The following is a description of a gene set: Adult onset Human Gene Set: HP_ADULT_ONSET studied in species Homo sapiens Onset of disease manifestations in adulthood, defined here as at the age of 16 years or later., and this is the list of marker genes: DNAJC5, RPGR, TERB2, INF2, ESR2, CACNA1A, CTNS, IFT140, CATSPER2, LGI1, RBM20, HJV, KLHL7, FBN1, MATR3, TULP3, LYST, RCBTB1, CAV3, POGLUT1, SPG7, ATP5MC3, MSH3, RNF216, DES, NOTCH2NLC (NCBI Gene Id 101060315), MPV17, CRYBA2, BAG5, HMCN1, MFRP, DRC1, SETX, KCNJ5, GPIHBP1, NRIP1, SLC37A4, DDX41, UCHL1, AOPEP (aminopeptidase O (putative)), SLC2A10, SDHA, ABCC8, CFHR3, PRPF8, NPHP1, CARD9, PLG, SUFU, SSX1, ERLIN2 (ER lipid raft associated 2), CFAP58, MECR, HPRT1, RPS4Y2, DYSF, KLHL3, RNASEL, MT-TT, LRP5, STK33, HSFY1, GNB3, SPTLC2, CYLC1, THSD4, RFXANK, ATP1A1, KLKB1, UMOD, FN1, TMEM126B, CIB1, TLR8, NLRP7, WRN, SLC44A4 (solute carrier family 44 member 4), CEL, OBSCN, FIG4, SOST, ELOVL4, DPY19L2, KCNH2, BVES, ZFHX3, PNPLA6, PLIN4, ZSWIM7, DMD, FHL1, PKP2, ITPR3, CD164, ABCG8, SCN4A, TLR7, CPT1C, GNB4, SLC30A8, MYPN, FOXC1, RRAGD, COL2A1, SMAD4, EIF2AK4, ATXN2, RILPL1, RAB39B, SOCS1, ATL3, KLHL24, FTL, TNNT2, SERPINH1, ITPR1, LIPC, NR3C1, SEC61A1, CNTNAP2, BPY2, TNFRSF13C, GCM2, CACNB4, PANK2, ARL2BP, PLD3, CADM3, ANO5, CASQ2, HSPB1, IMPG2, ABHD12, SDHB, SLC39A14, SYCP2, G6PD, KRAS, TTC19, ERCC6, TRPM7, SLC19A3, FGA, BRCA2, USP26 (NCBI Gene Id 83844, ubiquitin specific peptidase 26), RAPGEF2, SLC4A4, SPATA22, GPD2, SLC22A12, OPTN, WNT4, ANLN, PNKP, MEIOB, NR0B1, MSH6, KCNQ1, LHB, RAX2, LMNA, LRRK2, MAPKBP1, BSCL2, CAV1, SERPINA6, MORC2, PRKN, STAT1, HKDC1, HINT1, ABCC9, ADGRG2, FGF14, NOL3, KCNJ2, RNF170, ANXA5, NEK8, TTR, DNAJB6, SDHC, DNAH17, M1AP, MME, RETN, SLCO2A1, FOXL1, CCND1, PMP22, SGO1, CHRNA1, BRCA1, COL6A2, NPC1, MCM6, MYORG, MYL2, PRKG1, NOTCH3, AURKC, POLRMT, THBD, VPS16, HCN4, ATP7B, CLCN1, MEI1, TMTC4, UBA1 (ubiquitin like modifier activating enzyme 1), TNNC1, DIAPH2, CDH1, FBLN5, LRIF1, FKBP6 (NCBI Gene Id 8468), CHEK1, BMP6, LBR, GJC2, SMN2, PMVK, LITAF, DNAJB11, FARS2, GATAD1, DYRK1B, KCNJ11, TAF1, STARD7, ZMYND15, CLN6, CATIP (ciliogenesis associated TTC17 interacting protein), MCAT, F8, COQ2, FHOD3, EPAS1, LIG3, JPH2, CACNA1I (calcium voltage-gated channel subunit alpha1 I), TARDBP, IFIH1, GK (glycerol kinase), CASR, NEFL, COQ8B, SLC4A11 (solute carrier family 4 member 11), TGM6, SLC26A1, F5, NTHL1, FOXE3, TTC21A, SCN2B, DNMT1, CYP27A1, DRD5, TENM4, SMN1, GABRA3, TECRL, PDE11A, LMF1, C1QBP, PATL2, LOX, PLIN1, TRPC3, NT5C3A, MYBPC3, PDGFB, GALC, TBP, ATXN1, VEZF1, PNPLA2, RTEL1, EIF2B3, AARS2, ERBB4, CCDC62, ARMC12, TNNT1, HNRNPDL, ANO3, NLRP2, ANO10, DNAJC30, LIG4, CDC20, THOC1, CCDC88C, MPZ, AKT1, HMGCR, USP9Y, POF1B, HAMP (hepcidin antimicrobial peptide), TBC1D24, TAPBP, CC2D2A, TRPC6, TCF7L2, GIPC1, STAG3, LYZ, TAF4, SCNN1G, NFKB1, HK1 (NCBI Gene Id 59333), C1QTNF5, TEX11, SNCA, TNC, DNMT3B (NCBI Gene Id 1789), APOA1, RIPOR2 (RHO family interacting cell polarization regulator 2, NCBI Gene Id 9750), TCF4, SLC26A8, PTEN, PRPF4, OTC, TNFAIP3 (TNF alpha induced protein 3), ABCA7, SMARCA4, SFRP4, SH3BP2, WEE2, CRYAB, ITM2B (integral membrane protein 2B), CFI (NCBI Gene Id 3426), SLC4A3, LMX1B, PSEN2, CPOX, PIGA, DSC2, DAZ2 (NCBI Gene Id 57055), NUTM2B-AS1, MAPKAPK3, CORIN, SYCP2L, SLC4A1, NLRP5, YEATS2, DHTKD1, PRPH2, GNAL, SRPK3, SEPTIN12, MYH6, PRRT2, CDH23, ZP1, XRCC2, SCN5A, CEP78, RP1L1, PPOX, RBM12, PDK3, HFM1, MAPK8IP1, SMPX, CCDC146, SPTLC1 (serine palmitoyltransferase long chain base subunit 1), SCN4B (sodium voltage-gated channel beta subunit 4), RFC1 (replication factor C subunit 1), PIK3CA, RAF1, MMACHC, MFAP5, ARMC5, GDF9, KCNH5, KIF5A, COL6A3, IL36RN, CYP11B1, CAPNS1, POLE, SYNE1, MSH5, LAMA2, VPS35 (NCBI Gene Id 91808), ICOS, FAT2, TDRD9, TRIM32, TBC1D8B, SDHD, MFSD8, STRC, PABPN1, MPEG1, AARS1, RPL10L, KASH5, COL4A3, NEFH, CYLD, TWNK, DAZ3, UBQLN2, GCGR, SNCAIP, RP2, SEC23B, ATN1, DNHD1, PPP1R3A, SLC17A8, CDY1, PLAU, NAF1, LRRC23, ZNF687, SEMA3A, ATP1A2 (NCBI Gene Id 93186), EFEMP1, HTRA1 (NCBI Gene Id 5654), BCL10 (NCBI Gene Id 8915), PRPF6, JAK2 (Janus kinase 2), HNF4A, BEAN1, BLVRA, CHD8, SOX9, SOD1, GCNA, GBE1, ZP3, APP, MARCHF6, VCY, NPTX1, STT3A, PRDM10, ELMOD3, ADH1C, TERC, DSG2, ATP13A2, SLC25A4, TUBA4A, SYNJ1, C9, TRDN, CAPN1, REEP6, MAP1B, GGCX, CNBP, HNF1A, NEXN, GNPTAB, HROB, TUBB4A, FDPS, ARHGEF18, RBMY1A1, APPL1, PIK3R5, SNORD118, NHLRC1, VCP (valosin containing protein), SCO2, SEC63, TBK1 (NCBI Gene Id 29110), GGN, C14orf39, PDHA2, AAAS, MGME1, PDX1, PHKA1, CYP7B1, IRS1 (insulin receptor substrate 1), SUN5, NAGLU, DNAH8, GSN, REC114, HSPB8, MBD4, GBA1 (glucosylceramidase beta 1), CT55, XKRY, HRG, MAPT, MYH7, POT1, VPS13D (vacuolar protein sorting 13 homolog D), CFHR1, AAGAB, ACTL7A, PARN, DPM3, NR2E3, FSHB, TBX3, KCNJ18, TTBK2, ATXN10, MAFA, ATP1A3, CSF1R, TP63, ALDH5A1 (NCBI Gene Id 7915), TPP1, HAVCR2, LCAT, PMP2, PLAAT3, PALB2, MCM2 (minichromosome maintenance complex component 2), BRDT, QRICH2, CACNA1C, TCAP, VSX1, TEX15, IGF2BP2, EIF4G1, TMEM240, SPACA1, FANCM, SCN1B, GDAP2, SLC20A2, CCNF, CLEC3B, TSGA10, JUP (NCBI Gene Id 3728), LRP12, SPTAN1, KCNE1, DCTN1, SAMD12, DNAJB2, CLDN16, FBXO43, NF2, ABCC1, IRS2, KCTD17, TREX1, APTX, MEFV, AFG3L2, THAP1, NAA60, SLC17A9, JAG2, C19orf12, SPAG17, DAZ1, CTNNA1, MTOR, CATSPER1, VAPB, PRDX3, YARS1, ACR, TOP3A, USP48, GANAB, SAMD9L, SCN3B, MICAL1, AMACR, JPH3, HNRNPA1, MARS1, FMR1, LPL, BAP1, VCL, HNRNPA2B1, SH3TC2, PYGM, SGCD, RIGI, DIABLO, AP5Z1, THSD1, KIF1B, TRNT1, ANKH, SLC4A2, VHL (von Hippel-Lindau tumor suppressor), SASH3, TBX18, TIE1, ASTL, HLA-DRB1, RPGRIP1, NRCAM, HMGA1, TMEM43, ATP2B2, CHMP2B, PLA2G6, TERT, DSP, GBF1, ANXA11, DNM1L, MANF, TPM1, TTLL5, ZEB1, MUC1, CDH2, KCNE2, TOR1A, DIAPH3, CCIN, ALG10B, CHCHD2, SERPING1, LZTR1, IQCN, MED25, TSPOAP1, ELOVL5, SMCHD1, NEUROD1, MEN1, DNA2, PAX4, VAMP1, ABCA4, MOG, ACD, SHANK3, SMARCB1 (NCBI Gene Id 6598), GNAS, INS, WASHC5, MTNR1B, PRKRA, DTNA, PRKCSH, ALG5, TFG, MCCC1, DAB1, VRK1, MFN2, WFS1, NRL, PPARG, KPNA7, ATP6AP2, CHRNA2, RP1, CNNM2, MN1, TNPO3, NT5C2, HNF1B, ACTG1, FLNC, NF1, CFAP43, PTF1A, SLC19A2, APC, FKTN, BLK, STOX1, GATA2, INSR, CFAP251, SCN1A, GRN (granulin precursor), DGKE, SCN10A, TAF4B, STIM1, RRM2B, KCNA5, WDR19, SLC2A2, TIMP3, NDUFS2 (NADH:ubiquinone oxidoreductase core subunit S2), PRLR, AK7, PSEN1, ATP6V0A1 (NCBI Gene Id 535), TNNI3 (troponin I3, cardiac type), FSIP2 (NCBI Gene Id 401024), PAX2, PRKAG2, PDGFRB, KCNC3, SCD5, SPRY2, NOS3, PTPN1, PIGT, MYZAP, BMPR2, XRCC1, LIPE, COL4A1, POLG, PPP2R3C, ACVR1B, POLG2, C3 (NCBI Gene Id 12266), ALDH18A1, XK, LDB3, REEP1, ENPP1, C2CD6, KCNK3, AIP, SLC25A13 (NCBI Gene Id 10165), EIF2AK2, UNC119, HLA-DQB1, TK2, SCARB2, EEF2, GARS1, GNAI2, PLEKHG5, KCND3, CFAP61, XPR1, PRDX1, SMPD1, FZD4, GCK, EXTL3, CASK, CDY2A (chromodomain Y-linked 2A), BBS2, AUH, ZFP36L2, MSH4, HSPB3, AKT2, CTSF, VPS13C, DRAM2, ATP11A, TRPV4, TRPM3 (NCBI Gene Id 80036), ATL1, CFH, ABCB4, RNASEH1, STK11, HGSNAT, CLCN2, TSC1, PRDM16, LRP6, PRNP, TOR1AIP1, OXGR1, PDE8B, CBFB, PSAP, TRMT5, SOHLH1, KNG1, ATXN8OS, CFAP44, COQ4, VPS13A, ANO1, SNTA1, SFTPA1, IDS, IMPG1, PDYN, MOS, SMARCE1, GYG1, PRPH, CMPK2, ARHGEF10, PNLDC1, TEX14, CEBPE, DNAH1, NPPA, STUB1, RBP3, TGFBI, NAGA, CCDC39, SERPINA1, NEK1, PKD2, SYCP3, RPA1, B2M, HGD, CHCHD10, MYOT, CCDC34, SSBP1, ACTN2, AR, PKHD1, CP, MYL4, IKZF1, CPT2, DNALI1 (dynein axonemal light intermediate chain 1), BTNL2, UNC13D, TNRC6A, ALOX5AP, SPINK2, TIA1, KRT18, BPGM, SLC34A2, AKAP3, IFT74, PRKAR1A, ACTA1, GAA, TINF2, SDHAF2, PARK7, ERCC6L2, MAK, CSRP3, LAMA4, MLH1, TTN, NOP10, IL6, EPCAM (NCBI Gene Id 4275), TP53, TERB1, SMAD2, COCH, B4GALNT1, KDM5D, PLCZ1, SYCE1, RYR2, VPS11, MAFB, H6PD, MEF2A, PDE1C, SAMD7, DNAJC3, TYROBP, APOE, DNAJB4, C9orf72 (NCBI Gene Id 73205), RELN, MARS2, MIEF1, BAG3, ENG, FTH1 (ferritin heavy chain 1), TSC2, ATXN3, DDX3Y, PCYT1A, ACTC1, SLC7A6OS, SLC12A5, GFAP, POLD1 (NCBI Gene Id 5424), NLRP3 (NLR family pyrin domain containing 3), P2RX2, SPG11, DGUOK, RRM1, RET, TRIP13, KCNU1, TLCD3B, SELENBP1, GJA5, MPO, MOV10L1, AGBL1, PLN, GNA11, EPHA10, RPS14 (ribosomal protein S14), NR4A2, ZPBP, DLST, MB, UQCRC1, ENO3, TRRAP, SHOC1, MAGT1, TGFBR1, CAPN3, MSH2, ZNF408, MOCOS, PRKCH, F2, GNE (NCBI Gene Id 81868), RPS19